Given this list of marker genes PLCG1-AS1, RN7SKP100, MAFB, RNU2-52P, ENSG00000229771, EMILIN3, LPIN3, LINC01734, NEFHP2, RPL12P11 (NCBI Gene Id 128467), ZHX3, ENSG00000212224, RPL23AP81, ADI1P1, RN7SL615P, MIR6871, CHD6, ATG3P1, LINC01370 (NCBI Gene Id 100507770), TOP1, RNU6-1018P, ENSG00000229042, HSPE1P1, PLCG1, RNA5SP484, RN7SL680P, PTPRT-AS1, here is a description of the gene set: studied in species Homo sapiens Human Gene Set: chr20q12